Given this list of marker genes PPARD, SERPINE1, MIR140, ABHD2, NDRG4, MIR214, MIR223, TPM1, LRP1, GNA12, MIR182, BMP4, MIR638, SLIT2, BMPR1A, NF1, CORO1B, IGFBP3, MIR362, MIR1298 (microRNA 1298), MIR15A, PTPN1, MIR665, MYOCD, MIR137, MIRLET7B, MEF2C, MIR34A, SEMA6D, MIR503, AIF1, IGFBP5, PRKG1, MIR424, ADIPOQ, TRIB1, GSTP1, MIR218-1, MIR21, NFE2L2, here is a description of the gene set: Any process that stops, prevents, or reduces the frequency, rate or extent of smooth muscle cell migration. species: Homo sapiens Human Gene Set: GOBP_NEGATIVE_REGULATION_OF_SMOOTH_MUSCLE_CELL_MIGRATION